The following is a description of a gene set: Any process that modulates the frequency, rate or extent of endopeptidase activity, the endohydrolysis of peptide bonds within proteins. species: Homo sapiens Human Gene Set: GOBP_REGULATION_OF_ENDOPEPTIDASE_ACTIVITY, and this is the list of marker genes: VSIR, SEMG1, SERPINB1, A2ML1, RECK, FETUB, TIMP1, SERPINB8, MBP, CR1 (complement C3b/C4b receptor 1 (Knops blood group)), PSENEN, SERPINB3, CRB2, SPOCK2, SEMG2, SERPINB13, GAPDH, SPOCK3, SERPINB9 (NCBI Gene Id 5272), PRELID1